Given this list of marker genes PTGS2 (NCBI Gene Id 5743), ALOX15, LTA4H, ALOX15B, ALOX5, HPGD, ALOX5AP, PTGES, ACOX1, CYP4F3, AKR1C3, PTGDS, PTGIS, here is a description of the gene set: species: Homo sapiens Human Gene Set: MODULE_148 Genes in the cancer module 148.